Given this list of marker genes DEXI, CYTH2, ECHDC2, DPP4, EXOSC7, ENOSF1, NELL2, GIMAP6, PKM, IFITM3, NUCB2, RASA3, B4GALT3, CTDP1, LRCH4, RPL34, SF3A3, PPM1G, NIPAL3, DEF6, RANGAP1, TMEM115, TOB1, ITPKB, TIMP1, PBXIP1, R3HCC1, TSC22D4, UPP1, KLHDC3, FKBP5, IL27RA, SLC2A4RG, KIF22, BCL11B, EGLN2, ID2, CD2, PRKCH (protein kinase C eta), M6PR, DYNLT1, ABHD14A, LDHB, GBP2, KLHL21, DDX28, RBM42, RNF115, CITED2, ARHGEF1, CD3D, RGS10, SAMHD1, NMRK1, ATP13A2, RUNX1, ITM2A, FYB1, BEX3, IFITM1, UBASH3A, TRPV2, LEF1, ITGA6, PLAAT4, CTSD, RTN4, NOSIP (NCBI Gene Id 51070), ITGAL, SERINC3, SMPD1, NME3 (NME/NM23 nucleoside diphosphate kinase 3), CLPP, FMNL1, PSMD1, RTN3, PXN, ARRB2, BBLN, DOCK9, MVP, GYPC, PRKCQ (protein kinase C theta), TMEM11, USP20, ATP1A1, LTBP4, HMG20B, RIOX1, LPIN2, MPG, ZNHIT2, TRNAU1AP, ADNP2, ACAA2, GRSF1, MRPL12, NRBP1, ARL4C, PRMT2, DNAJB1, HAX1, DUSP7, FXN, TXK, SIGIRR, INPP4B (NCBI Gene Id 8821), ANXA1, BCL7C, SRGN, MED15, GIMAP5, KCNAB2, IL32, SELENOW, GATA3, ETHE1, CDR2, HMOX2, NDFIP1 (NCBI Gene Id 80762), YIPF5, EVI2A, DGKA, INPP4A, LEPROTL1, SEMA4D, FLT3LG (NCBI Gene Id 2323), TXN2, SORL1, SCAP, EEIG1, PSMC1, DHX30, CEP68, TSPO, GZMM, MAL, SELPLG, ENO2, TECR, THYN1, DGKZ, GBP1, SPOCK2, CD3E, ACTG1, LIME1, UNC119B, CASP6, CD7, GLRX5, PPP2R1A, LY6E, RNF167, IL7R, GMPS, TBCD (tubulin folding cofactor D), PPP6R1, BTN3A3, MSL1, CCND2, RSL1D1, TPI1, TACC3, TRABD, NBR1, HIPK1, PITPNC1, EMC6, ADGRE5, BTN3A1, LCK, CD27, MOGS (mannosyl-oligosaccharide glucosidase), PRKCA, CD3G, AIFM1, SMARCA4, DYRK2, GRPEL1, RNF187, ZYX, CABIN1, RHOG, IL17RA, PLCG1, RRS1, SAE1, ITK, CD247, RGCC, SAMSN1, TNFRSF1A, WWP1, STAT5B, PGAP6, APBB1IP, TRAC, ZAP70, here is a description of the gene set: species: Homo sapiens Human Gene Set: GSE22886_TCELL_VS_BCELL_NAIVE_UP Immune cell-specific expression is one indication of the importance of a gene's role in the immune response. In order to identify such patterns, we set out to broadly profile gene expression in a variety of immune cells. from publication Abbas AR, Baldwin D, Ma Y, Ouyang W, Gurney A, Martin F, Fong S, van Lookeren Campagne M, Godowski P, Williams PM, Chan AC, Clark HF (PMID 15789058) Genes up-regulated in comparison of naive CD4 CD8 T cells versus naive B cells.